The following is a description of a gene set: The portion of the plasma membrane surrounding a neuron projection. Mouse Gene Set: GOCC_NEURON_PROJECTION_MEMBRANE studied in species Mus musculus, and this is the list of marker genes: Shisa9, Thy1, Adgrv1, Ddn, Ripor2 (RHO family interacting cell polarization regulator 2), Vezt, Tacr3, Grin2a, Clrn2, Gria1, Ppp1r9b, Adora1, Ank1, Hcn1, Sgce, Myo1c (myosin IC), Atp6ap2, Gabre, Gabra3, Trpc2, Epb41l3, Reg1, Lamp5, Robo1, Kcnh1, Slc1a2, Adora2a, Atp2b2, Nradd, Stx4a, Insr, Akap5 (A kinase anchor protein 5), Sptbn1, Kcnc3, Palm, Gabbr1, Atf4, Gabrg1, Cacng8, Slc9a5, Shisa7, Gper1, Gabra1, Hpca, Grin1, Atp2b1, Cacna1d, Mapk8ip3, Gabarapl1, Ush2a, Shisa6, Mapt, Trpv1, Oprm1, Dagla, Unc5a, Clcn2, Myo1d, Mcoln3, Cntnap2, Itga8, Kcnc4, Wls, Oprd1, Ngfr, Kcnj11, Kcnb1, Gabrg2, Gabrg3, Chrna7, Robo2, Gabra5, Gria2, Hcn2, Kcnc2, Mpp2, Gabra6, Shisa8, Gabra2, Slc12a5, Gabra4 (NCBI Gene Id 14397), Kcnc1, Pkhd1l1 (NCBI Gene Id 192190)